The following is a description of a gene set: Human Gene Set: GSE14413_UNSTIM_VS_IFNB_STIM_RAW264_CELLS_DN Cytoplasmic DNA triggers the activation of the innate immune system. While downstream signaling components have been characterized, the DNA sensing components remain largely elusive. We performed a systematic proteomics screen for proteins that associate with DNA, traversed to a screen for IFN-β-induced transcripts. We identified DSIRE (DNA sensor for the IL-1β response, previously called AIM2) as a candidate cytoplasmic sensor. DSIRE showed a marked selectivity for double-stranded DNA. DSIRE can recruit the inflammasome adaptor ASC and gets redistributed to ASC speckles upon coexpression of ASC. RNAi-mediated reduction of DSIRE expression led to an impairment in IL-1β maturation. Reconstitution of unresponsive cells with DSIRE, ASC, caspase 1 and IL-1β showed that DSIRE is sufficient for inflammasome activation. Overall, our data strongly suggest that DSIRE is a cytoplasmic DNA sensor for the inflammasome. from publication Bürckstümmer T, Baumann C, Blüml S, Dixit E, Dürnberger G, Jahn H, Planyavsky M, Bilban M, Colinge J, Bennett KL, Superti-Furga G (PMID 19158679) studied in species Homo sapiens Genes down-regulated in RAW264.7 cells (macrophage): control versus stimulated with IFN-b., and this is the list of marker genes: HEBP1, SULT6B1, KRT15, ALOX12B, BMP8A, SRD5A2, GABRD (NCBI Gene Id 2563), SLC44A5, FADS3 (NCBI Gene Id 3995), DUSP13B, DUSP29, KDM4B, FHL1 (NCBI Gene Id 2273), INSYN2A, LYVE1, MIR452, MRAP2, SEPTIN12, E4F1, WAS, FBXO46, AGER, PIK3C2G, AMIGO3, ANK3, LSMEM2, COX4I2, MOCS3, SLC35G2, ADAMTS19, NGB, PNPLA1, OVOL3, SLC20A2, ZBTB7C, GRHL3, CHRNE, APOB, BAIAP3, RTN1, SCRG1, PCDH19, NMBR, OLFM2, MIR9-3, BCL2L10, MMP25 (matrix metallopeptidase 25), ADRA1D, CNTN2, FCER1A, SLC1A3, KDELR3, VWA5A, PKHD1, KCNH5, FCAMR, TSPAN1, KLHL31, GPR161, AWAT2 (NCBI Gene Id 158835), GLI1, PBLD, APOF, ACTN2, MIR499A, GUCY2EP, HCAR2, CD34, NLGN3, ANKRD1, AATK, ANKRD61, LRFN2, USH2A, FZD3, SPRR3, PDE6G, DPYSL3, CORO6, CLEC1A, THNSL2, CHRNA7, ZSCAN22, NKX3-1, TENT5D, RBBP8NL, HS6ST2, KRTAP5-3, MYRIP, RFX6, ATP13A4, PCLO, TTYH1, SLC7A9, NPY1R, ZDHHC11, ARAP3, ANO7, TMEM217, PLPP7, TRIM40, SEC31B, NHLRC4, ISLR, IL1A, DIP2C, CETN1, BCAR3, EMX1, MIR195, UCMA, FHDC1, ALPI, SMPX, KIRREL3, VSX1, PCDH18, NKX1-2, TMCC2, FBXO43, DPYSL4, HOXA5, MSRB2, MAPK4